The following is a description of a gene set: from publication Amit I, Garber M, Chevrier N, Leite AP, Donner Y, Eisenhaure T, Guttman M, Grenier JK, Li W, Zuk O, Schubert LA, Birditt B, Shay T, Goren A, Zhang X, Smith Z, Deering R, McDonald RC, Cabili M, Bernstein BE, Rinn JL, Meissner A, Root DE, Hacohen N, Regev A (PMID 19729616) Human Gene Set: GSE17721_LPS_VS_POLYIC_16H_BMDC_DN Genes down-regulated in comparison of dendritic cells (DC) stimulated with LPS (TLR4 agonist) at 16 h versus DC cells stimulated with poly(I:C) (TLR3 agonist) at 16 h. studied in species Homo sapiens mouse primary BMDCs were stimulated with tlr ligands and gene expression changes were profiled on Affymetrix arrays, and this is the list of marker genes: LPIN3, TAX1BP3, LTC4S, FAM120A, CENPB (centromere protein B), PSMB6, XPO6, RSAD2, CCL4, MAD2L1BP, NCK2, CDH11, OAS2, AVL9, BRD2, KHDC4, ADTRP, TMBIM6, ARL14EP, ZNF740, FAM89A, IFIT3, ZNF385A, BFAR, VAPB, SEZ6L2, MRPL39, PARP9, PRPF38A, SCN1B, ATP6V1G1, HMBOX1 (homeobox containing 1), RTF2 (replication termination factor 2), DDX60, CLK2, ENC1, YTHDF1, AANAT, TLE6, SPPL3, TANGO2, BLOC1S3, HMGN3, MDM4, YWHAH, RBMS1, RHOV, ACTR3, CD86, PPFIA4, PSRC1, NRROS, CEPT1, NUDT9, ADAM23, MRC1, LRP1, SLC7A8, PLEKHA2, GLIPR2, TOB2, ECE2, PLEKHO2, PTK6, ZNF292, NAXE, HS1BP3, PGLYRP1, SLC15A4, PLEKHO1 (pleckstrin homology domain containing O1), NPEPPS, HDAC5, ZXDC, SOCS6, TSPAN5, GSAP, ZP1, SPHK1, NFE2L1, ARR3, ZFP36L2, NDRG4, JARID2, SEMA4F, TRIM25, CCR5, IZUMO1R, SIRT7 (sirtuin 7), FAM53C, PARP12, MYO10 (NCBI Gene Id 4651), UTRN, IL12RB2, GCNT2, RBBP8, TPX2, MMD, RIPPLY3, TXNDC17, FGFRL1, SYNGR2, ALDH1L1, LDLR, FAM117A, CACNB4, HELZ2, DCBLD2, TSPAN13 (tetraspanin 13), SYN3, RAB8B, RNF13, TBC1D8, CCNE1, EDN1, SNF8, NAA80, TLK2, STAP2, PTPRF, CCNA1, UBXN1, CCNJ, EIF4EBP1 (eukaryotic translation initiation factor 4E binding protein 1), KDR, TRIOBP, SLC44A2, ATF1 (NCBI Gene Id 466), GMPPB, LPGAT1, IL2RB, B3GAT1, EFCAB7, EFNB2, GRINA, SCARB2, E2F3, CLK1, C15orf39, COCH, NLGN2, CCDC12 (coiled-coil domain containing 12), TRPM6, ARFGAP3, CTSK, RAB22A, NUB1, SLC43A3, EIPR1, OMD, RBM43, BCAT1, ORM1, LGALS1, MAGI1, RIN2 (Ras and Rab interactor 2), CHD8, SAT1, SNX4, PTGS1, IL21R, KRT20, TMEM131L, IGLL1, MMP19, RYR1, KAT2B, PXN, SOX4, SNRK, TBC1D13, FAM227B, PRDM5, MFHAS1, ZBTB18, RBMS2, SBF2, PARVG, CTDSP1, PHYHD1, YPEL1, CHMP1A, IRF2, IP6K1, MTA1, SERPINB1 (serpin family B member 1), MOCOS, C8orf33, USP15, STAT4, S100A11, NR3C1, CAMK2D, SERTAD1, ATP13A1, L1CAM, F11R (NCBI Gene Id 50848), TOX, RTN4, SPIN1, MANSC1